Given this list of marker genes SMAD6, DNMT3B, WDFY2, SESN1, PRKAR1A (NCBI Gene Id 5573), CTBP2, KLF4, FGF8, PARP8, ZIC2, DDAH1, INHBA, CRTC1, ACVR2B (NCBI Gene Id 93), PBX3, MIR141, BCORL1, MIR200A, SOX2, ASCC3, SETD2, DLL1, MSGN1, FOXH1, POU5F1, PAX6, RGS10 (regulator of G protein signaling 10), TCF7L1, WDHD1, CCDC88A, SNAI1 (snail family transcriptional repressor 1), SOX17, WNT3, TWSG1, WDCP, UBR5, JAK2, ZFHX4, AEBP2, SLC2A12, WNT3A, TBX3, C9orf72, TET1, SRF, SOX21, ELP4, RPL38, SCHIP1, FZD4, HPRT1, FOXA1, PIAS1, LATS1, TRIM5, FOXC1, MIR373, ACVR2A, TEAD1, AHDC1, LEFTY2 (NCBI Gene Id 96286), GDF3, SMAD3, SMAD1, DKK1, PRKACA, AXIN1, RARG, HTT, AMH, PITX2, PPP2CA, ATP8B2, CEP250, TOX3, SMAD2, MIXL1, EOMES, JARID2, NODAL, TRERF1, ACVR1, TEAD2, TEX56P, TBX6, EPB41L5, TOX, ELK4, BHLHE40, MACF1, BMPR2, ADAM19, MIR372, MIR375, CCDC6, NLK, CUL4B, GATA3, AXIN2, ARL4A, NFE2L2, EMSY, FGFR1, HNF4A, RARB, EXT2, FOXA2, TRIM28, HAND1, NOG, NANOG, SMAD4, MIR125B1, CHRD, ZIC5, YAP1, ZNF462, MTF2, DIP2A, PHF6, FZD8, BMPR1A, TCF4, MIR302C, MEIS1, LEFTY1, PBX1, CSRP2, ACACA, HMGA2, C1QBP, BMP4, TRIM71, GATA6, LEF1, HES7, ZNF281, PLCH1 (NCBI Gene Id 23007), NCAPG2, ARID5B, FOXC2, BMP7, TBX1, EXT1, CCND1, MBTD1, NABP2, FZD5, KDM6A, ZIC3, GRHL2, KLF5, VAV3, here is a description of the gene set: Mesodermal commitment pathway Human Gene Set: WP_MESODERMAL_COMMITMENT_PATHWAY species: Homo sapiens